Given this list of marker genes AURKC, INCENP, MAP10, KIF4B, RACGAP1, CDCA8, PRC1, LZTS2, AURKB, KIF23, MLH1, CCDC69, KIF4A, BIRC5, here is a description of the gene set: Human Gene Set: GOBP_SPINDLE_MIDZONE_ASSEMBLY The cell cycle process in which aggregation, arrangement and bonding together of a set of components to form the spindle midzone. The spindle midzone is the area in the center of the spindle where the spindle microtubules from opposite poles overlap. studied in species Homo sapiens